The following is a description of a gene set: studied in species Homo sapiens Any process that activates or increases the frequency, rate or extent of hematopoietic stem cell proliferation. Human Gene Set: GOBP_POSITIVE_REGULATION_OF_HEMATOPOIETIC_STEM_CELL_PROLIFERATION, and this is the list of marker genes: THPO, ATXN1L, KITLG, WNT1, WNT10B, PDCD2, WNT5A, N4BP2L2, KAT7